Given this list of marker genes NFYA, LOX, SMAD2, KANSL3, BARHL1, TRAK2, HNF4A (hepatocyte nuclear factor 4 alpha), GJA5, PPP1R1B, MFAP2, SLC25A35, MN1, MARCKS, NEUROG3 (neurogenin 3), BAHD1, SLCO5A1, KCNJ13, VAC14, ZNF148, KLF13, CHD6, SEL1L, GRM3, UCK2, SMURF2, UQCRFS1, NUCB2, RCOR2, POU3F3, COPZ1, PHACTR3, TMEFF1, SHC3, LHX1 (LIM homeobox 1), SLC4A2, CCT7, STRADB, USPL1, RAVER1, GPC3, LHX4, SLC24A4, OTX2, BTG4, GK, MARK3, NCDN, PRDM5, SSBP3, SCUBE3, NONO, ZC3H10, HOXB3, CNOT3, CEP20, TAFA4, UBE2S (ubiquitin conjugating enzyme E2 S), LUC7L3, PNRC1, OLIG2, CDCA3, HEPACAM, NOL4, EMSY, CCDC71, NKX3-1, NDP, NAV3, DDX4, LAMP2, IRS1, ENSG00000204117, ANKS1B, SSH2, C1QTNF1, MNT, DNAJC11, SPRY2, DGKZ, ZBED5, SP3, COL5A3, LMO4, AMD1, SC5D, ACTR1A, SOX9, SYCP3, OARD1, DENR, PLA2G3, UBE2E3, OSTF1, SOX14, PPP1R9B, GNG8, TTBK2, DIS3L2, SUFU, ETV4, HLA-DRB1, ZIC1, SOX4, HLX, SORBS2, IL6ST, UBB, RBFOX2, CCDC88A, SNCA, MEX3D, ATP2A2, PAX3, TPI1P2, ZFAND4, ERBB2, C12orf57, H2AZ2, KLHDC9, CCDC33, SND1, HIP1, SKIDA1, ZNF423, FHIP1B, TLK2 (NCBI Gene Id 11011), ABLIM1, TFDP2, WNT3, TLE3, FGF10, NFATC4, DYRK2, NUBPL, PKN2, CCAR1, PPP2R5C, CYP24A1, CALD1, CCDC140, HSCB, GATA6, RAB35, PTPRK, DPYSL3, ANGPTL2, MEIS1, DNAH5, ANKHD1-EIF4EBP3, SMAD6, TBX2, LAMA1, NMRK1, ABCB5, SFRP1 (secreted frizzled related protein 1), GPBP1, LINC02875, NALF2 (NCBI Gene Id 27112), CCNE2, SALL1, SPTAN1, MAP2K6, IL4, MEPE, ELAC2, STC1, USP21, EIF4G2, CDK5, RCN2, PRDM1, GJB4, KIF23, TSGA10, ANKHD1, IP6K2, SPATA20, FGF20, DLL1, NMNAT2, CDH3, NNAT (NCBI Gene Id 4826), PLEC, ATP13A4, SEL1L3, TDO2, SAMM50, SOX2, PSME4, YIPF4, ETV5, CHAC1, TMEM160, OLFML3, ST8SIA2, PAIP2, SP140L, TNFSF11, RAB5B, ZFY, LASP1, SESN3, IL6, UTP18, HOXB9, TSC22D3, ZNF516-DT, GPR85, HSPB2, SMAD3, CNBP, JPT1, USP5, IL25, NAGLU, ZNF385B, MAZ, MEX3B, RPL41, SLC6A4, OSTC, DLX1 (NCBI Gene Id 1745), NFYB, PDYN, RNF10, ACR, RNF38, ATRNL1, WDR81, TENM1, TTC39C, FIZ1, IL17B, TTC16, SIX1, ACKR3, SYNCRIP, ESPL1, EIF4A1, HOXA6, LRP6, PRADC1, HNRNPLL, NIPBL, PTMA, TACC3, HLA-DQB2, PAK2, STARD7, TMEM204, LINS1, ZNF454, NID2, RECK, LAT, SMYD1, SPATA32, ZNF524, AGBL2, CAP1, TP53INP2, OPCML, HOXC5, ASB7, ACTB, TMEM129, TNFRSF21, FOXH1, GRHL3, CNN3, RERE, TNPO3, PALS1, PIGS, DDX5, JMJD1C, SLC20A1, CITED2, IKZF2, GGNBP2, CDH1, CLEC18C, FYN, SLC38A4, STAG2, VCP, EPHA3, SHKBP1, DUSP6, LRRC36, ANO4 (NCBI Gene Id 121601), HOATZ, F2, ABHD12, HMGA2, NFIB, CYLD (CYLD lysine 63 deubiquitinase), ZIC4, NREP, YIPF7, ECEL1, TTYH1, FERD3L, LETM2, CEP95, SLC43A2, ENAM, MIR22HG, CDK17, ITGB8, here is a description of the gene set: from publication Xie X, Lu J, Kulbokas EJ, Golub TR, Mootha V, Lindblad-Toh K, Lander ES, Kellis M (PMID 15735639) Comprehensive identification of all functional elements encoded in the human genome is a fundamental need in biomedical research. Here, we present a comparative analysis of the human, mouse, rat and dog genomes to create a systematic catalogue of common regulatory motifs in promoters and 3' untranslated regions (3' UTRs). The promoter analysis yields 174 candidate motifs, including most previously known transcription-factor binding sites and 105 new motifs. The 3'-UTR analysis yields 106 motifs likely to be involved in post-transcriptional regulation. Nearly one-half are associated with microRNAs (miRNAs), leading to the discovery of many new miRNA genes and their likely target genes. Our results suggest that previous estimates of the number of human miRNA genes were low, and that miRNAs regulate at least 20% of human genes. The overall results provide a systematic view of gene regulation in the human, which will be refined as additional mammalian genomes become available. species: Homo sapiens Genes having at least one occurrence of the highly conserved motif M78 GCTNWTTGK in the regions spanning 4 kb centered on their transcription starting sites. The motif does not match any known transcription factor binding site. Human Gene Set: GCTNWTTGK_UNKNOWN